Given this list of marker genes MMP19, CD59, APC, NME2, PXN, IGF2R, IGFBP2, RHOQ, RHOA, ZYX, ITGB5, LAMA4, RND3, IGFBP5, here is a description of the gene set: Despite major advances in the understanding of the intimate mechanisms of transforming growth factor-beta (TGF-beta) signaling through the Smad pathway, little progress has been made in the identification of direct target genes. In this report, using cDNA microarrays, we have focussed our attention on the characterization of extracellular matrix-related genes rapidly induced by TGF-beta in human dermal fibroblasts and attempted to identify the ones whose up-regulation by TGF-beta is Smad-mediated. For a gene to qualify as a direct Smad target, we postulated that it had to meet the following criteria: (1) rapid (30 min) and significant (at least 2-fold) elevation of steady-state mRNA levels upon TGF-beta stimulation, (2) activation of the promoter by both exogenous TGF-beta and co-transfected Smad3 expression vector, (3) up-regulation of promoter activity by TGF-beta blocked by both dominant-negative Smad3 and inhibitory Smad7 expression vectors, and (4) promoter transactivation by TGF-beta not possible in Smad3(-/-) mouse embryo fibroblasts. Using this stringent approach, we have identified COL1A2, COL3A1, COL6A1, COL6A3, and tissue inhibitor of metalloproteases-1 as definite TGF-beta/Smad3 targets. Extrapolation of this approach to other extracellular matrix-related gene promoters also identified COL1A1 and COL5A2, but not COL6A2, as novel Smad targets. Together, these results represent a significant step toward the identification of novel, early-induced Smad-dependent TGF-beta target genes in fibroblasts. Cluster 3: ECM related genes up-regulated in dermal fibroblasts within 30 min after TGFB1 addition; returned rapidly to basal level after that. studied in species Homo sapiens from publication Verrecchia F, Chu ML, Mauviel A (PMID 11279127) Human Gene Set: VERRECCHIA_RESPONSE_TO_TGFB1_C3